Given this list of marker genes PEX10, PEX6, USP9X (NCBI Gene Id 8239), PEX1, PEX5, PEX12, PEX2, here is a description of the gene set: The process in which peroxisome targeting sequence receptors dissociates from cargo proteins and are returned to the cytosol. studied in species Homo sapiens Human Gene Set: GOBP_PROTEIN_IMPORT_INTO_PEROXISOME_MATRIX_RECEPTOR_RECYCLING